Given this list of marker genes AASS, DHFRP1 (dihydrofolate reductase pseudogene 1), QDPR, DMGDH, SMOX, CRYM, DHFR2, PRODH2, PRODH, PYCR2, MTHFD1L (NCBI Gene Id 80244), ALDH1L2, MTHFD1, PAOX, NOXRED1 (NADP dependent oxidoreductase domain containing 1), MTHFD2, SARDH (NCBI Gene Id 8017), BLVRB, PYCR1, MTHFD2L, PIPOX, AIFM2, MTHFR, ALDH1L1, ETFDH, PYCR3, DHFR, here is a description of the gene set: species: Homo sapiens Human Gene Set: GOMF_OXIDOREDUCTASE_ACTIVITY_ACTING_ON_THE_CH_NH_GROUP_OF_DONORS Catalysis of an oxidation-reduction (redox) reaction in which a CH-NH group acts as a hydrogen or electron donor and reduces a hydrogen or electron acceptor.